The following is a description of a gene set: C57Bl/6 wild-type and STAT6 KO mice were used to study PPARg and IL-4 signaling. Bone marrow of 3 mice per group was isolated and differentiated to macrophages with M-CSF (20 ng/ml). 20 ng/ml IL-4 was used to induce alternative macrophage activation and 1 uM Rosiglitazone (RSG) was used to activate PPARg. From each mouse 4 samples were generated: 1. M-CSF, 2. M-CSF+RSG, 3. IL-4 and 4. IL-4+RSG. All compounds were added throughout the whole differentiation process, and frech media was added every other day. Control cells were treated with vehicle (DMSO:ethanol). After 10 days, RNA was isolated and gene expression profiles were analyzed using Mouse Genome 430 2.0 microarrays from Affymetrix. from publication Szanto A, Balint BL, Nagy ZS, Barta E, Dezso B, Pap A, Szeles L, Poliska S, Oros M, Evans RM, Barak Y, Schwabe J, Nagy L (PMID 21093321) Human Gene Set: GSE25088_CTRL_VS_IL4_AND_ROSIGLITAZONE_STIM_MACROPHAGE_DN Genes down-regulated in wildtype bone marrow-derived macrophages: control versus treated with IL4 and rosiglitazone. species: Homo sapiens, and this is the list of marker genes: ZNHIT1, MRPS30, SCARA3 (scavenger receptor class A member 3), TIGD1, TAF4, CD6, PPP2R2D, PPP2R5C, GPC3, MYL12A, ANXA4, IDS, ATL3, SPINDOC, INTS15, PRADC1, NDUFC2, CDKN2AIPNL, MAPK1, C1orf216, BLID, PTPRN2, EP400P1, APMAP (NCBI Gene Id 57136), KCNB2, TXNL4A, TNFSF12, FLJ30679, ARB2A, SON, COPZ2, SAP18, OR1D2, ELP6, RAD23A (RAD23 homolog A, nucleotide excision repair protein), MAGEH1, PDE6D, RAB5B, UGGT1, RPA3, ZNF394, BTD, DOK1, SERPINI1, ATP8B1-AS1, ELOC, EDN3, GALNS, TTL, ZNF682, MAST3, KRTCAP2, PRKCQ, NUP210, CD3G, DTYMK, SLC26A2, ZFPM2, DDOST, RAB6A, IGFBP7, GRAMD2B, CYB5A, ARIH2, TM7SF3, BTBD6, FAM83G, PEX14, ZNF391, SCAND3, SNAPC3, DPY19L2P2, GSTM3, SLC13A3, PCID2, STIM1, ATP5IF1, ADIPOR2, GLG1, PLOD1, NRXN2, POGLUT3, CTNNA1, HIF1AN, SCP2, MAP3K7, CYTIP, LAMP1, PPP6R1, FAM117A, KRT2, TRAPPC10, IRF2, INPP5A, KIAA1143, ZCCHC14, KIAA2013, ALG1, OSTM1, MBLAC2, STMN3, PIN1, HSP90B1, CD3D (NCBI Gene Id 915), RNF169, LYRM7, HS6ST1, GLRX, PIGK, GBA1LP, UQCRFS1, RUNX1 (NCBI Gene Id 861), FBXW5, CRELD1, HRG, ARSA, PELP1, CCT7, P3H4, INSYN1, EIF4EBP2, GRK5, DDX60, GDPD1, LINC00615, ERBB2, CHST2, GHDC, LINC01949, IGF2R, MOGS, TTC31, VLDLR, TRAPPC6B, TMED10, MFAP3, CHST12, TBCD, SWI5, TGFBR3, CAMLG, CCDC144A, PMM1, THAP9, KIR2DL1, SMPD1, RAB5IF, SNPH, STC2, RUSC1, WDR45, GNAL, GUK1, SLC1A7, IGFBP3, NFIL3, ANAPC7, PCSK5, PROS1, BNIP3 (BCL2 interacting protein 3), TBC1D22B, LIPT1, DLGAP1-AS1, TMEM106C, CTBP2, MYEOV, NLRX1, LPCAT1, MPC2, TMEM208, TMCC1, NF2, CELSR2, MACC1, ZBTB8OS (NCBI Gene Id 339487), SRSF7 (serine and arginine rich splicing factor 7), FTO, LRPAP1, LPAR5, REEP1, FCGR3B, CXCR2, JRKL, GOT1, LRIF1, PPAT, SAMD9L, FAM120AOS, MITD1 (NCBI Gene Id 129531), NCSTN, CSMD2-AS1, SPON2, SLC39A11, CEP72, APBA2